Given this list of marker genes GOLGA8CP, SMPD3, GOLGA8M (NCBI Gene Id 653720), GOLGA8T, GOLGA6A, SLC30A5, XYLT1, GOLGA8J, GOLGA6C, GOLGA8S, GOLGA8K, SLC30A7, ATL1, NECAB3, GOLT1A, GOLGA8H, GOLGA8Q, GOLGA8IP, GOLGA8B (golgin A8 family member B), GOLGA8R, NSG2, GOLGA8DP, GOLGA6D, GOLGA8N, GOLGA6B, GOLGA8A, LLGL1, GOLGA2, GOLGA8O, TMEM59, here is a description of the gene set: The Golgi cisterna closest to the endoplasmic reticulum; the first processing compartment through which proteins pass after export from the ER. species: Homo sapiens Human Gene Set: GOCC_GOLGI_CIS_CISTERNA